The following is a description of a gene set: Mouse Gene Set: GOBP_HEMATOPOIETIC_PROGENITOR_CELL_DIFFERENTIATION studied in species Mus musculus The process in which precursor cell type acquires the specialized features of a hematopoietic progenitor cell, a class of cell types including myeloid progenitor cells and lymphoid progenitor cells., and this is the list of marker genes: Bcl2, Adar, Samd9l, Pld4, Ston2 (stonin 2), Hrnr, Psen1, Nfe2l2, Fancb (Fanconi anemia, complementation group B), Serpinb9f, Plek, Batf, Zfp36, Rbm47, Shh, Sos2, Foxc1, Mir181c, Mettl3 (methyltransferase 3, N6-adenosine-methyltransferase complex catalytic subunit), Braf, Trp53, Hes1, Sp1, Runx1, Flt3, Rlig1, Sirpa, Lyn, Ap2a2, Tet2, Dock1, Ciao3, Prkdc, Xrcc4, Mrgprx1, Ssbp3, Kat5, Tmem143, Hoxb3, Slc8a3, Abca15, Tmem91 (NCBI Gene Id 320208), Lmbr1l, Fbxo21, Cebpd, Gata3, N4bp2l2, Tmem190, Cdk6 (NCBI Gene Id 330039), Agpat5, Psen2, Siglecg, Mir193b, Ptpn6, Esco2, Mir99a (NCBI Gene Id 387229), Zfp784, Sipa1l3 (NCBI Gene Id 74206), Zbtb1, Notch1 (notch 1), Mmp21, Sbds, Kitl, Eif2ak2, Inhba, Vmn1r13, Gm36723 (predicted gene, 36723), Pus7, Pcid2, Atf2 (NCBI Gene Id 97033), Dnai4, Med1, Rara, Col24a1, Mllt3, Hes5, Fstl3, Fas, Krt75 (keratin 75), Hmga1, Zfat, Ptprc, Kcnab2, Srf, Krtap5-5, Arl11, Rest, Mirlet7e, Ext1, Chd2, Kit, Tmsb4x, Herc6, Ptprz1, Tcf15, Flt1, Anln, Tnfrsf13b, Meox1, Muc4, 4930474N05Rik, Prrc2c, Bves, Top2a, Slc37a4, Sox4, Atf7, Eef2, Ptprq, Tcaf2, Mir130a, Dhtkd1, Il3, Vegfa, Lipa (lysosomal acid lipase A), Nudt21, Dpf2, Vmn1r214, Sp3, Znhit1, Mixl1, Dock7, Hoxb4, Ap3b1 (NCBI Gene Id 97864), Lig4, Kcp, Thsd1, Sfrp1, Mir126a, Hspa9, Flcn, Fst, Rrs1 (NCBI Gene Id 98201), Kdr, Serpinb12, 3830403N18Rik, Hyal2, Setd1a, Ppp4r2, Mettl14, Mlf1, Mir125b-2, Smpd3 (sphingomyelin phosphodiesterase 3, neutral), Apobec3, Mir542, Sos1, Dact2, Tal1, Terc, Zfp980, Mir155, Spi1, Ufl1, Eml1, Gata2, Wdr7, Armc6, Gpatch4, Jam3, Srsf4, Tgfb1, Cited2, Trex1, Muc19, Heatr9, Tent2, Zbtb24, Slc7a6os, Pygo1, Sp7, Tifab, Xrcc5, Arhgef7, Ankle1, Myb, Bmp4, Fnip1, Hmgb1, Sin3a, Zswim9, Pdgfra, Ercc2, Pdcd2, Ythdf2, Mir125b-1, Vmn2r74, Wdr38, Dhx36, Sh2b3, Cyp2c66, Acp6, Rbmy